Given this list of marker genes PSMA4, PSMB2, OAZ3, PSMB7, PSMD11, PSMC6, PSMC3 (NCBI Gene Id 96121), PSMD6, PSMC1, AZIN1, ODC1, PSMC4, NQO1, PSMA6, PSMD14, PSMA7, PSMD12, OAZ1, PSMD3, PSMB3, PSMB1, PSMA3, PSMD8, PSMC5, PSMB4, PSMD1, PSMA2, SEM1, PSMB6, ADRM1, OAZ2, PSMD13, PSMC2, PSMD2, PSMA1, PSMA5, PSMB5, PSMD7, here is a description of the gene set: Reactome Pathway: Regulation of ornithine decarboxylase (ODC) studied in species Homo sapiens part of: Metabolism of polyamines Polyamines increase the production of antizyme (AZ). The carboxy-terminal half of antizyme interacts with ODC, generating an inactive AZ:ODC heterodimer complex. A carboxy-terminal domain of ODC is exposed only within the heterodimer, and is the target for subsequent degradation. A domain within the amino-terminal portion of antizyme provides a function needed for efficient degradation of ODC by the proteasome. <br>The proteasome cycle starts with the processing of AZ:ODC, sequestering ODC and then degrading it to peptides but releasing AZ. AZ participates in additional rounds of binding and degradation. Antizyme-mediated inhibition and destruction of ODC reduces synthesis of polyamines. Additionally, antizyme also inhibits polyamine transport into the cell. Antizyme production is reduced, completing the regulatory circuit.